Given this list of marker genes IL2RB, TMED11P, MME-AS1, CD3G, CD96, KLRC1, CRTAM, BIRC3, NCR3, CD247, ENSG00000267568, IL7R, TTC16, TRAT1, TCL1A, CYTIP, SH2D1B, KLRK1, FCRL3, CCDC88C, CD5, IL32, SLAMF1, LTB, CCR6, TRAF3IP3, IGHM, PLAAT4, RUNX3, IL12RB2 (interleukin 12 receptor subunit beta 2), LY9, RASGRP1, IGHD (immunoglobulin heavy constant delta), SLFN12L, CD79B, ACAP1, IGKC, PYHIN1, MS4A1 (membrane spanning 4-domains A1), GZMA, TBX21 (T-box transcription factor 21), SULT1B1, LINC01192, CD3D, SYTL3, P2RX5, SLAMF6, JCHAIN, KLRC2, SH2D2A, LINC01478, ADAM8, TIGIT, BCAS1, PTPN22, CD8A, KLRB1, BTLA, MYBL1, FCRL1, IRF4, SELL, BACH2, RHOH, KLRC4-KLRK1, GZMB, TBC1D10C, IL2RA, ITK, GPR18, NT5C3AP2 (NT5C3A pseudogene 2), CARD11, IKZF2, DUSP2, ZNF831, PTPRCAP, LINC00426, IL18RAP, CD27, GPR171, FCRL2, BLK, ISG20, YWHAH-AS1, ZAP70, KLHL14, CD2, TRBC2, PCED1B-AS1, COL4A4, S1PR5, CRIP1, MZB1 (marginal zone B and B1 cell specific protein), KLRF1, SEPTIN1, LINC01606, CD8B, CST7 (cystatin F), EOMES, CCR7 (C-C motif chemokine receptor 7), SLAMF7, PAX5, TMIGD2, CD244, UBASH3A, SPTSSB, SLFN5, NKG7 (natural killer cell granule protein 7), KLRC3, CD3E, CD160, NPM1P7, TMEM154, GALNT3, LINC00861, IL2RG, HLA-DOB, PRF1, ADGRG3, LINC01934, CD19, TCF7, NCR1, CD52, LAX1, TRDC (T cell receptor delta constant), GZMH, GZMM, HSH2D, GZMK, IFNG-AS1, FCMR, MATK, SIT1, P2RY10, CXCR5, PTGDR, XCL1, FCRL5, SPIB, CDC42EP3-AS1, FCRLA, LINC01215, IGLL1, ICOS, ZNF550, IRGM, SH2D1A, DTHD1, SYTL1, IKZF3, THEMIS, PLAC8, ARPP21, CD7, LINC02542, SKAP1, CD79A, LCK, NIBAN3, GNLY, ENSG00000259097, NOG, MYO1G, GBP5, here is a description of the gene set: The gene expression program underlying the specification of human cell types is of fundamental interest. The study authors generated human cell atlases of gene expression and chromatin accessibility in fetal tissues. For gene expression, the study authors applied three-level combinatorial indexing to >110 samples representing 15 organs, ultimately profiling ~4 million single cells. The study authors leveraged the literature and other atlases to identify and annotate hundreds of cell types and subtypes, both within and across tissues. Our analyses focused on organ-specific specializations of broadly distributed cell types (such as blood, endothelial, and epithelial), sites of fetal erythropoiesis (which notably included the adrenal gland), and integration with mouse developmental atlases (such as conserved specification of blood cells). These data represent a rich resource for the exploration of in vivo human gene expression in diverse tissues and cell types. from publication Cao J, O'Day DR, Pliner HA, Kingsley PD, Deng M, Daza RM, Zager MA, Aldinger KA, Blecher-Gonen R, Zhang F, Spielmann M, Palis J, Doherty D, Steemers FJ, Glass IA, Trapnell C, Shendure J (PMID 33184181) Marker genes curated from the annotated cluster as represented in the Descartes Human Gene Expression During Development database. Human Gene Set: DESCARTES_FETAL_ADRENAL_LYMPHOID_CELLS studied in species Homo sapiens